The following is a description of a gene set: species: Homo sapiens Interrupted aortic arch Non-continuity of the arch of aorta with an atretic point or absent segment. Human Gene Set: HP_INTERRUPTED_AORTIC_ARCH, and this is the list of marker genes: MMP21, GATA6, KDM6A, PLXND1, MYCN, CHD7, FGFR1, TMEM260, KMT2D, TBX1, SMG9, KRAS (NCBI Gene Id 3845), DGCR8, SEMA3E, SUCLG1, FOXF1, DGCR6, DIS3L2, ESS2, MYRF, NKX2-6, DGCR2